Given this list of marker genes SV2A, STIM2, PKD2, F2RL3, HTR2A, LETM1, TRPC4, CHRNA7, HTT, BCL2, BOK, HCRTR1, CCR7, NTSR1, IBTK, JPH2, GP1BA, GRINA, ATP6V1B1, ATP2B1, RYR2, CCR1, ITPR2, GP9, PIK3CB, ITPR1, CCL23, TPCN2, EDN3 (endothelin 3), PDPK1 (NCBI Gene Id 5170), ATG5, TGM2, TNFSF11, ATP13A5, MCUB, EDN2, MAIP1, DHRS7C, TSPOAP1, MICU2, GSTM2, LIME1, CNR1, PSEN1, FGF23, SLC24A4, TRPV4, CACNA1S, STIM1, CCL19, MICU1, CCL15, PTH1R, CCL7, TMEM38A, YWHAE, FAM3A, CCL21, TMTC4, CYBA, PLCB2, ASPH, SMDT1, CTRC, WBP2NL, F2, PLCG1, BAX, PSEN2, DMTN, MIR1-1, P2RY6, CALM1, ATP13A2, CALM3, FKBP1B, CAV3, THADA, ATP13A1, ATP2A3, ATP13A3, PLCB4, EDN1, CACNB2, TRPC7, PRKACA, CDH5, GRM1, NPY, HRC, C19orf12, ATP1A2, KCTD17, PLCL2, BAK1, PLCL1, VAPB, LCN6, DRD1, GRM5 (glutamate metabotropic receptor 5), DRD3, CLCC1, MIR133A1, MCU, TRPM8, TPT1, CCL8, KDR, CD40, CACNB4, GHITM, PTPRC, ERC2, RMDN3, P2RX7, OSBPL2, APLNR, TGFB1, FZD9, TMBIM6, APOE, ITPR3, CCL5, CCL11, TUNAR, SLC8B1, ATP2B3, FAM20A, CORO1A, PRKCB (NCBI Gene Id 5579), P2RX1, MICU3, CAV2, MIR93, SLC8A1, SLC24A2, GPR12, DRD5, PLN, XCL1, MYH7B, CIB2, RYR3, PDE4D, CAV1, ATP2B4, PLCH1, ATP2C1, IMMT, MTLN, ZNHIT1, ANK2, PKHD1, SELENOK, TNNI3, PACS2, JPH3, ALPL, NGF, AKAP6, ATP2C2, ITGB3, HTR2B, PRKD1, TMTC2, XK, TMEM178A, ERO1A, NPSR1, P2RY1 (purinergic receptor P2Y1), THY1, GPER1, LCK, STC2, RYR1, IL13, TRPV6, TMEM203, SLC8A2, PDZD8 (PDZ domain containing 8), CALB1, DISC1, METTL21C, CIB3, CAPN3, PLCB1, GRID2IP, SLC10A7, MCOLN1 (NCBI Gene Id 57192), TRDN, DMD, CALCB, DIAPH1 (NCBI Gene Id 1729, diaphanous related formin 1), CDH23, DDIT3, NOL3, CCL3, HCRTR2, RAP1GDS1 (Rap1 GTPase-GDP dissociation stimulator 1), FKBP1A, PLCB3, CCL1, PTH, CLIC2, RGN, DRD2, CCL14, SGCD, SLC24A5, JPH4, CXCL9, TMEM64, KEL, SPPL2C, CCR2, ATP2B2, CALM2, PLCG2, PML (PML nuclear body scaffold), CASR, STC1, LYN (NCBI Gene Id 4067), SLC24A1, TRPC1, CAMK2D, FGFR1, GSTO1, SNCA, PRKCE, GP5, VDR, GCM2, DMPK, CCL13, HERPUD1, ATP2A1, SELENON, ATP1B1, BDKRB1, LETMD1, CX3CL1 (NCBI Gene Id 6376), CXCL12, AFG3L2, STOML2, KL, XCR1, TRPM2, CALCA, UMOD, ATF4, WNT5A, WFS1, CASQ1, WNK4, CD19, ATP7B, TMCO1 (transmembrane and coiled-coil domains 1), ADORA1, TRPC5, HTR2C, SLC35G1, DRD4, MCUR1, NPTN, BNIP3, FATE1, UBASH3B, SV2B (synaptic vesicle glycoprotein 2B), CHERP, PTK2B, SYPL2, NT5E, PLCH2, CXCR3, VPS54, CALR, CHD7, CASQ2, GRIN1, ANKH, CYP27B1, SLC25A23, CSRP3, GP1BB, TRPA1 (NCBI Gene Id 8989), KCNK16, HEXB, HSP90B1, CCDC47 (coiled-coil domain containing 47), CEMIP, FGF2, F2R, TMEM38B (transmembrane protein 38B), ADCY8, SNX10, CXCL11, ABCC6, CALB2, PTPN6, ANXA6, CXCL10, CACNA1C, LACRT, SLC8A3, ELANE, FASLG, PLCE1, CCR5, CNGB1, TRPC3, JPH1, TRIM24, S100A14, SRI, CLN3, EDNRA, HAP1, ATP13A4, TRPC6, TCIRG1, NPPC, SLC30A1, GRIK2, FLNA, ATP2A2, TRPV5, SLC25A27, SLC24A3, TMEM165, ABL1, here is a description of the gene set: species: Homo sapiens Any process involved in the maintenance of an internal steady state of calcium ions within an organism or cell. Human Gene Set: GOBP_CALCIUM_ION_HOMEOSTASIS